The following is a description of a gene set: from publication Chen Y, Wang X (PMID 31504780) Human Gene Set: MIR3059_3P studied in species Homo sapiens Genes predicted to be targets of miRBase v22 microRNA hsa-miR-3059-3p in miRDB v6.0 with MirTarget v4 prediction scores > 80 (high confidence targets)., and this is the list of marker genes: MED20, RBM15B, ZNF99, ALMS1, RPL22, ELF5, ZCRB1, TBX5, DNA2, SRGAP2B, TNRC6B, ABCC5, SLC39A9, KLF8, CSN1S1, SKP1, TAOK1, CLCN6, CR2, NLRP12, CHP2, CUL2 (cullin 2), LTB4R, SRGAP2C, PPP1R16B, ENTPD2, PSMB9, MORC3, SNRK, ITCH, EEIG2, MRPL17, SERINC4, MMP16, IHH, CHEK1, DENND3, UFM1, ERLIN1, PPP4R4, LIN7C, CCDC65, HNF4A, SLC22A23, RELA, CACNG6, FBP1, GEMIN8, GTDC1, WDR6, ZNF398, ARL6IP1